Given this list of marker genes PPARA, SPX, LEP, CARTPT, GDF15, NPFF, BBS4, GFRAL, MKKS, GHSR, UCN (urocortin), NENF, BBS2, here is a description of the gene set: Any process that stops, prevents, or reduces the frequency, rate or extent of a response to nutrient levels. Human Gene Set: GOBP_NEGATIVE_REGULATION_OF_RESPONSE_TO_NUTRIENT_LEVELS species: Homo sapiens